Given this list of marker genes MIAT, EVI2A, BAG3, FXYD5, CD69, NT5E, ASB2, BBLN, VPS29, ASAH1, MYO1E, GPR68, FAM20A, OTULIN, SIRT3, CDKN1A (cyclin dependent kinase inhibitor 1A), C1orf21, STX11, PDGFA, SAMD9L, RGS1, BSCL2, KCTD10, RHOF, CCNG1, S100A6, CYB5R4, TENT5A, STX7, NIBAN2, VPS50, SERTAD1, COTL1, MLKL, NDFIP1, CRYBG2, F2RL2, NKG7, HMGCS1, PGLYRP1, ROM1, BATF3, ENDOD1, EGR3, GFOD1, TNFRSF11B, IFI30, CD63, HSD11B1 (NCBI Gene Id 3290), EMP1, XBP1, LAG3, SLC52A3, DHRS11, TSPO, CD244, IFNG, GPR18, TMBIM4, SERPINB6, SLC19A2, LGALS3, ZCCHC18, H1-2, NFIL3, BATF, CCND2, MED11, TUBA1C, SRGAP2, B4GALNT4, PLP2, DYRK3, ITGAE, TMEM158, ARFGEF3, CYP51A1, GPC1, SH3BGRL3, PRRC1, RAB19, OSBPL3, GLIPR2, B4GALNT2, KLHL30, IER3, HK2, PLSCR1, AQP9, TNFRSF9, TNFSF10, SLC39A4, TMEM154, PDLIM7, CD9 (NCBI Gene Id 928, CD9 molecule), LTA, CCDC102A, SCIMP, IFITM1, ST3GAL6, TIRAP, UPP1, DUSP6, GCNT1, P2RY14, SULT2B1, EPOP, SERPINE2, EMILIN2, FTL, SNX18, BHLHE40, IRGM, SH3BP2, NEURL3, IQGAP2, ZNF296 (NCBI Gene Id 89860), GNG2, LGALS3BP, PLCG2, UAP1L1, VTI1B, LAT2, CCL3, TMEM126A, SYTL2, TMEM238, FNBP1, HBA2, CLDND1, GRAMD1B, ANKH, PDZK1, APOBR, KIR3DL1, CDKN2B, DAPK2, ADGRG5, TYROBP, NFKB1, CCL5 (NCBI Gene Id 8147), CDKN2A, LTB4R, SMCO4, TIAM1, S100A11, S100A10, PLEKHO2, ARL6IP5, NAPSA, KIT, FCER1G, KIAA1671, GSTP1, VASH1, LRRK1, CALHM6, GPR15, ALDOA, VIM, HHEX, FCGR2A, SCIN, KLK8, EHD4, CXCL9, RAB3D, TAF9B, IRAK2, RIOX2, CLNK, TPST2, MAPKAPK3, PLPP2, RNF19B (NCBI Gene Id 127544), XCL1, PPP3CC, CXCR3, HVCN1, MT1F, NCF4, GLIPR1, ARSB, CSTB, CCR5, CD7, S100A13, SLC2A6, CD52, SMAGP, TUBB6, FHL2, CX3CR1, HLA-B, TF, SERP2, SH2D1B, ID2, KLRD1, CCL4, CASP1, PRR7, ITGB7, S100A1, CTNNA1, PIM3, AHNAK, MYO1F, TMEM141, TNF, SIDT1, GDPD5, TMEM120A, ZBTB32, SELENOS, C15orf48, IFITM3, DOK2, CAPZB, SERPINA3, DCXR, S100A4, FOSL2, MSMO1, ERRFI1, SDF2L1, DUSP5, LY6G5B, CRYBG1, MYO1G, MYL6, PRDX4, CHSY1, HAVCR2, GBP2, DENND3, KHNYN, SUSD3, LRRC8C, TFDP1, ARAP3, SEMA4A, SLC24A3 (solute carrier family 24 member 3), FURIN, LITAF, FXYD4, OSTF1, OSM, MINDY1, CD160, HGFAC, GLRX, IL18R1, LASP1, ELOVL1, PTMS, CAPN2, AVIL, PRMT2, PPIB, GOLM1, ZNF608, RBMS1, PEA15, CCN2, ANXA2, PRR13, JUNB, NRGN, SCCPDH, DENND4A, MED10, FAM185A, HOPX, CTSW, F2R, MFSD10, TRAF1, SGK1, SPP1, MVP, GPR34, CORO1C, ARF6, PLTP, SEC61B, CAPG (NCBI Gene Id 822), SLAMF7, LGALS1, JAML, EGR1, B3GNT8, IFITM2, CXCR5, PRELID2, ECI1, SYPL1, PKP3, CAPNS1, TRPM6, GCNT2, HAAO, FES, GADD45G, RAB4A, TNFRSF18, TES, CISH, LMNA, ADGRG3, CASTOR1, ITGAD, COMT, LRP12, PIGZ, here is a description of the gene set: from publication Li P, Burke S, Wang J, Chen X, Ortiz M, Lee SC, Lu D, Campos L, Goulding D, Ng BL, Dougan G, Huntly B, Gottgens B, Jenkins NA, Copeland NG, Colucci F, Liu P (PMID 20538915) Human Gene Set: LI_INDUCED_T_TO_NATURAL_KILLER_UP T cells develop in the thymus and are critical for adaptive immunity. Natural killer (NK) lymphocytes constitute an essential component of the innate immune system in tumor surveillance, reproduction, and defense against microbes and viruses. Here, we show that the transcription factor Bcl11b was expressed in all T cell compartments and was indispensable for T lineage development. When Bcl11b was deleted, T cells from all developmental stages acquired NK cell properties and concomitantly lost or decreased T cell-associated gene expression. These induced T-to-natural killer (ITNK) cells, which were morphologically and genetically similar to conventional NK cells, killed tumor cells in vitro, and effectively prevented tumor metastasis in vivo. Therefore, ITNKs may represent a new cell source for cell-based therapies. species: Mus musculus Genes up-regulated in ITNK cells (T-lymphocyte progenitors (DN3 cells) reprogrammed to natural killer (NK) cells by ablation of BCL11B gene), compared to the parental DN3 cells.